Given this list of marker genes ADAM17, MBOAT1, THUMPD1, USP49, SLC16A1, DHRS1, BZW2, RAPGEF2, ANKRD34C, CNIH1, RAF1, PAFAH1B2, SIAE (sialic acid acetylesterase), CXCL12 (NCBI Gene Id 6387), USP35, KCMF1, ZDHHC15, POLE, CBFA2T3, ZBTB44, CRCP, PFDN2, SRD5A3, SNRPB2, PLEKHG3, IRGQ, DNASE1L1, STRN4, RAD51C, NCOA6, NOP16, ZC3H14, ILVBL, ANXA10, PDXK, JADE1, SLC30A6, PCDHB14, TBXA2R, NEDD4L, TIMM44, NCOA2, GTF2E2, ZNF276, OSBPL11, BUB3 (NCBI Gene Id 9184), ATP6AP2, CDC42EP4 (NCBI Gene Id 91740), JADE3, SFXN1, WNT5A, ELOVL1, CTXN3, TSPAN9, TNFSF14, ATG2B, MZT2B, C2CD2, LLGL2, ABCE1, TMEM104, ABCG2, SPSB3, CNPY3, LY9, TCEAL8, SMURF2, PHF8, BORCS5, RBPJ, TAF5, ADPGK (ADP dependent glucokinase), SEC22C (NCBI Gene Id 9117), LEPROTL1 (leptin receptor overlapping transcript like 1), NUMB, ELOC, RNF31, NPC2, GPHN, ERCC3, PSMF1, SRPRB (NCBI Gene Id 58477), NUDT7, HDAC5, BCL2L13, CLCN1, CCDC32, SNORA16A, CRIM1, LONRF1, GCH1, WSB2, COX10, AZI2, PMPCA, RANGAP1, MGAT1, CCDC51, TSPAN4, GOSR2, JOSD2, ARFIP2, CFHR1 (complement factor H related 1), GYS1, CTSC, PMEPA1, RBM8A, CLTC, CD79B, PLEKHA1, TRIP6, ICE1, ZBTB17, TIMM22, ZFYVE19, RNF41, CCR1, GLRX, ZCCHC8, URB1, OXSR1, MKRN2, CYBC1, CLDND1, SNORA73A, PCCB, PDCD5, MOB1A, SHROOM2, WFDC8, NOD1, PLXNA1, RCE1, IKBIP, RETREG3, CACYBP, TMEM161A, POLR1A, GFI1, UTY, MEG3, MYO9B, ISL2, UST, EXD2, JMJD6, NDUFA8, GRWD1, HSF4, NDRG3, FGL1, CENPQ, VPS39, here is a description of the gene set: The transcription factor FoxP3 partakes dominantly in the specification and function of FoxP3+ CD4+ T regulatory cells (Tregs), but is neither strictly necessary nor sufficient to determine the characteristic Treg transcriptional signature. Computational network inference and experimental testing assessed the contribution of several other transcription factors (TFs). Enforced expression of Helios or Xbp1 elicited specific signatures, but Eos, Irf4, Satb1, Lef1 and Gata1 elicited exactly the same outcome, synergizing with FoxP3 to activate most of the Treg signature, including key TFs, and enhancing FoxP3 occupancy at its genomic targets. Conversely, the Treg signature was robust to inactivation of any single cofactor. A redundant genetic switch thus locks-in the Treg phenotype, a model which accounts for several aspects of Treg physiology, differentiation and stability. Human Gene Set: GSE40274_EOS_VS_FOXP3_AND_EOS_TRANSDUCED_ACTIVATED_CD4_TCELL_UP Genes up-regulated in CD4 T conv over-expressing: IKZF4 versus IKZF4 and FOXP3. from publication Fu W, Ergun A, Lu T, Hill JA, Haxhinasto S, Fassett MS, Gazit R, Adoro S, Glimcher L, Chan S, Kastner P, Rossi D, Collins JJ, Mathis D, Benoist C (PMID 22961053) studied in species Homo sapiens